Given this list of marker genes PEX10, PEX11B, BMPR1B, COL1A2, PEX7, PEX14, PEX19, PEX3 (peroxisomal biogenesis factor 3), RTL1, PEX6, GGCX, DLK1, FLNB, DDR2, AGPS, MEG3, PDE4D, GUSB, MGP, PEX16, VPS35L, DHCR7, EBP, LBR, NEU1, GNPAT, PRKAR1A, SNRPB, COL1A1, PEX13, NSDHL, PEX1, ARSL, PEX12, PEX26, PEX5, THRB, GDF5, PEX2, P4HB, here is a description of the gene set: studied in species Homo sapiens The presence of abnormal punctate (speckled, dot-like) calcifications in one or more epiphyses. Epiphyseal stippling Human Gene Set: HP_EPIPHYSEAL_STIPPLING